Given this list of marker genes MCC, FAM168B, MSX2, CLEC2D (C-type lectin domain family 2 member D), CALB1, MAGEA1, LRRC1, DHX32, MTSS1 (NCBI Gene Id 9788), ATP5MG, MAGEA4, ARL17A, OCRL, CFL2, PCDHB15, DNAJC22 (DnaJ heat shock protein family (Hsp40) member C22), AZIN1, MAGEA2, CEP192, EIF4B, CPM, ZBTB2, CYP2B6, NOC3L, SEPTIN6, LARP1B, RP2, TREM2, SYNPR, ATP1B2, DNAJC27, PLAA, L3MBTL3, URI1, SLMAP, PTPRN2, UBXN2B, WDR3, CUL3, CDYL2, ZNF676, EFTUD2 (elongation factor Tu GTP binding domain containing 2), RUFY2, RPL23A, EIF4A1, LIAS, GPATCH2, TNIP3, EPHA6, ADAM12, CCSER2, UBE3A, CBFB (core-binding factor subunit beta), SPATA8, SLITRK5, TRIO, SPATA9, ZRANB3, OGFR, SEMA3D, CD34, ZNF652, SEPTIN10, DBR1, BRWD1, COBL, MKLN1, FOXA1 (NCBI Gene Id 3169), OCA2, MAGEA6, ROCK2, G3BP1 (G3BP stress granule assembly factor 1), ATP11C, DNAAF4, MAGEA2B, PLEKHF2, BMP3, PLA2G2A, MTMR9, ADNP, LDLRAD1, GFM2, KAZALD1, DNAJC21, MAGEA12, GRK3, KRTAP9-8, C5orf24, GAS2L3, CLTRN, STK38, HTR1D, PANK3, TTC33, AKR7A2, KCNK2, TXN, LYSET, CDKN2C, SHROOM3, AGTR2, KIAA1549L, HDAC8, TNFRSF11B, IGSF1, STATH, PDIA5, NPVF, MAGI1, DCUN1D5, ZBTB33, ZNF728, MARK1, PCGF5, YES1, ACKR2, RBM41, YIPF6, WNK1, STON1, SQOR (sulfide quinone oxidoreductase), LGR4, SLC16A7, ENSG00000266560, RHOJ, DAZL, PDIA4, SLC7A6, TFPI, SDSL, POLR3K, MYLK4, CUL9, MDM1, KCTD6, MAGEA5P, LAMB4, BBIP1, TSN, IBTK, CNOT6, TAF2, TTPA, ZNF664, ME2, VAPB, RAB18, VAMP7, PTPRU, PLPP6, SPECC1, MBL2, TSPYL4, SPATA18, KATNA1, SHE, CACNA2D1, NCKAP5, ZBTB1, CDK19, TMEM109, NUP58, TCF4, RFX3, LMNTD1, ZSWIM6, ANKS1A, SRBD1, B3GALNT2, NUDT4, CCDC40, FRS2, IL22RA2, POLDIP3, PFN1, CCDC88C, GRIA4, PHLDA1, DCP1B, DMAC1, TMEM183A, KANSL1, HOOK3, KLHL34, PRTFDC1, SOX6, TULP3, CTNNB1, ZCCHC3, MINAR1, ZNF704, EFR3A, ANKRD28, ZC3H6, DNA2, RNLS, TMEM100, MIER1, MTUS1, USP42, SAMSN1, CRIPT, DCLK1 (doublecortin like kinase 1), IL19, MTX2, KRTAP9-4, PLXDC2, SLFN5, TMX3, EVI5, HOMER1, FBXO4, ARL13B, CNOT6L, TCEAL1, ASPHD2, EXOC6, SRP72, AAK1, RBM27, PARD6G (NCBI Gene Id 84552), PLEKHA2, RUFY3, TRUB1, EIF2S1, SOD2, SMPDL3A, LGSN, CCPG1, GRIK2, RTL8A, SCAF11, TFAM, PCGF3, NAALADL2, TBPL1, RAP2C, CFHR2, SPON1, ASCC3, CRYL1, KDM7A, SNAP25, MSANTD3 (Myb/SANT DNA binding domain containing 3), KCNC2, ST3GAL2, PROX1, DMC1, KRTAP9-3, SLC24A1 (NCBI Gene Id 9187), BPNT2, UBN2, ATAD5, ADAR, RBAK, THSD7B, WRN (NCBI Gene Id 7486), HNRNPH3, BCKDHB, PLCL1, UNC80, SPAG9, CCNA2, FER, HESX1, FANCC, KNDC1, SDHAF4, NFAT5, MAGEA3, SPOCK1, CETN3, GREB1, ZFR, TBC1D15, MEOX2, COPB1, ZC2HC1A, PRICKLE1, HYKK, GAB1, PIK3CA, KRTAP9-2, AFF1, PTGER3, MAN1A2, HOXA3, TOMM20, LPP, PAN3, LAMC1, PAX6, FZD3, here is a description of the gene set: species: Homo sapiens Genes predicted to be targets of miRBase v22 microRNA hsa-miR-892c-5p in miRDB v6.0 with MirTarget v4 prediction scores > 80 (high confidence targets). Human Gene Set: MIR892C_5P from publication Chen Y, Wang X (PMID 31504780)